The following is a description of a gene set: Binding to glycogen. studied in species Homo sapiens Human Gene Set: GOMF_GLYCOGEN_BINDING, and this is the list of marker genes: EPM2A, PPP1R3A, PPP1R3C, PPP1R3F, PPP1R3B, PPP1R3E, STBD1, PPP1R3D, PPP1R3G (protein phosphatase 1 regulatory subunit 3G)